The following is a description of a gene set: studied in species Mus musculus Mouse Gene Set: GOBP_TRANSCRIPTION_BY_RNA_POLYMERASE_III The synthesis of RNA from a DNA template by RNA polymerase III, originating at an RNAP III promoter., and this is the list of marker genes: Tbp, Snapc5, Polr3a, Brf1, Polr1b (polymerase (RNA) I polypeptide B), Bdp1, Brf2, Ar, Polr2b, Mybbp1a, Polr2a (NCBI Gene Id 20020), Rptor, Polr3b, Foxa2, Snapc3, Zc3h8, Prdx5, Mtor, Setd5, Gtf3c6 (NCBI Gene Id 67371), Polr1c, Ski, Dek, Ell, Tenm1, Baz1b, Dhx36, Chd8, Polr1d, Polr2e, Myo1c, Nab2, Maf1, Gtf3c5, Polr1a, Polr3h (NCBI Gene Id 78929), Smarca5, Ice2 (interactor of little elongation complex ELL subunit 2), Sf3b1, Polr2f, Polr3g, Ercc6, Crcp, Gtf3c4, Snapc1, Ddx21, Gtf3c3, Polr2l, Polr3gl (NCBI Gene Id 99549), Snapc4, Gtf3c2, Polrmt, Inhba, Polr3k, Gtf3c1, Polr3d, Ice1, Polr3f